Given this list of marker genes Fgf22, Fgf2, Pik3ca, Fgf20, Fgf5, Fgf23, Fgf10, Fgf17, Fgf3, Fgf9, Fgfr1, Kl, Gab1, Pik3r1 (NCBI Gene Id 328326), Fgf6, Ptpn11, Fgf8, Grb2, Fgf4, Frs2, Fgf1 (NCBI Gene Id 14164), here is a description of the gene set: PI-3K cascade:FGFR1 Mouse Gene Set: REACTOME_PI_3K_CASCADE_FGFR1 species: Mus musculus